Given this list of marker genes CAVIN2 (NCBI Gene Id 8436), ASAP1, BIN2, EHD2, FNBP1L, SNX33, DNM2, WHAMM, SNX18, PACSIN1, PACSIN3, SNX9 (sorting nexin 9), SH3GLB1, WASL, MICALL1, CHMP4A, BIN3, ATP10A, PACSIN2, here is a description of the gene set: Human Gene Set: GOBP_PLASMA_MEMBRANE_TUBULATION species: Homo sapiens A membrane tubulation process occurring in a plasma membrane.